Given this list of marker genes TXNDC5, CD48, PLXNA4, TMEM37, SH3RF2 (SH3 domain containing ring finger 2), PCK1, SERPINA10, AIM2, SPMIP5, PNLIPRP2, TUB, RGS7BP, TIAM1, SLC26A9, GPR17, CHRNA1, BLOC1S5, FUT11, CLDND2, GIMAP5, CD3G, OGFOD1, MARVELD1, GHITM, KRT82, TRPC4AP, DYNLT1, SYT13, ASXL3, RAPGEF1, FMOD, ITGB2, EFHD2, HOXA10, GIMAP1, DEFA1B, ARID5B, KRT76, TACR3, CD3D, CBX6, NLRP10, DEFA3, FAM90A1, NUDT21, DEFA1, ST6GALNAC1, here is a description of the gene set: We hypothesized that DNA methylation distributes into specific patterns in cancer cells, which reflect critical biological differences. We therefore examined the methylation profiles of 344 patients with acute myeloid leukemia (AML). Clustering of these patients by methylation data segregated patients into 16 groups. Five of these groups defined new AML subtypes that shared no other known feature. In addition, DNA methylation profiles segregated patients with CEBPA aberrations from other subtypes of leukemia, defined four epigenetically distinct forms of AML with NPM1 mutations, and showed that established AML1-ETO, CBFb-MYH11, and PML-RARA leukemia entities are associated with specific methylation profiles. We report a 15 gene methylation classifier predictive of overall survival in an independent patient cohort (p < 0.001, adjusted for known covariates). from publication Figueroa ME, Lugthart S, Li Y, Erpelinck-Verschueren C, Deng X, Christos PJ, Schifano E, Booth J, van Putten W, Skrabanek L, Campagne F, Mazumdar M, Greally JM, Valk PJ, Löwenberg B, Delwel R, Melnick A (PMID 20060365) Cluster 5 of aberrantly hypomethylated genes in blasts from AML (acute myeloid leukemia) patients. Human Gene Set: FIGUEROA_AML_METHYLATION_CLUSTER_5_DN species: Homo sapiens